The following is a description of a gene set: Induced Treg (iTreg) cells are essential for tolerance and can be used therapeutically, yet their stability in vivo and mechanisms of suppression are unresolved. Here, we used a treatment model of colitis to examine the role of autologous IL-10 in iTreg cell function. Mice treated with IL-10+/+ iTreg cells in combination with IL-10–/– natural Treg (nTreg) cells survived and gained weight, even though iTreg cells were numerically disadvantaged and comprised just ~20% of all Treg cells in treated mice. Notably, ~85% of the transferred iTreg cells lost Foxp3 expression (ex-iTreg) but retained a portion of the iTreg transcriptome which failed to limit their pathogenic potential. The TCR repertoires of iTreg and ex-iTreg cells exhibited almost no overlap, which indicates that the two populations are clonally unrelated and maintained by different selective pressures. These data demonstrate a potent and critical role for iTreg cell produced IL-10 that can supplant the IL-10 produced by nTreg cells and compensate for the inherent instability of the iTreg population. from publication Schmitt EG, Haribhai D, Williams JB, Aggarwal P, Jia S, Charbonnier LM, Yan K, Lorier R, Turner A, Ziegelbauer J, Georgiev P, Simpson P, Salzman NH, Hessner MJ, Broeckel U, Chatila TA, Williams CB (PMID 23125413) Genes down-regulated in comparison between in vitro derived induced T reg (iTreg) and converted ex iTreg. Human Gene Set: GSE35543_IN_VITRO_ITREG_VS_CONVERTED_EX_ITREG_DN studied in species Homo sapiens, and this is the list of marker genes: HOXA7, ATP11A, CCDC187, CXXC5, FNDC10, IFITM10, PEX11A, ARPC3, CABP4, GABRP, BMP6, DSG1, LPAR1, ICAM2, ENSG00000286190, GJA1, KRT31, NCS1, MINAR2, GNB5, TPST2, ECE1, POLD4, GRAMD4, CHCT1, SLC14A2, RASGEF1A, FYTTD1, TRIML1, DCAF11, TMEM191C, ST6GALNAC6, EGR2, PXMP2 (peroxisomal membrane protein 2), HOXA11, TSPAN5, LAG3, CRTAM, FMC1, ARID5B, NDUFS5, CORO2B, SLC48A1, TIMM8B, FHL2, SLC39A4, HLA-DQA1, RGL1, PAPSS1, SIPA1L3, ABCG5, MAGI1, MCOLN1, EPHB3, VSNL1, MTSS1, ZDHHC11, MRPS33, ZYX, NDFIP2, DGKZ, IKZF3, HPCAL1 (NCBI Gene Id 96763), MC5R, SLC15A3, ZFP36, SCN1B, TRIM8, TSPAN15, CAPN8, CD320, HOXD8, PENK, PRKN, HOXA1, KRT18, TMEM208, VPS29, GABRA1, PRRG2, DCLK1, CSNK2B, ADGRE5, NICN1, PPP3R1, NDUFS2, AP4S1, LDLRAD3, TMEM121B, RFTN1, TMEM115, MFNG, RBPJ, CD68, TIMP1, GLRX2 (glutaredoxin 2), MCRIP2, AKT2, FOXN1, IL27RA, MFSD13A, SLC22A9, CCR3, OTOR, SLC7A11, SULF1, HAPLN2, LGALS3, PFKM, ISYNA1, URGCP, COQ4, TCP11L2, BORCS6, CCL1, NAA10, LTBP3, HBG2, TCTA, C16orf90, SMPDL3B, CALU, PNKD, ADGRL1, RHOT2, GPRC5C, FBXO36, CDK3, CHIT1, NNMT, ANXA8, CCL24, COMMD10, BTBD19, KLF9, DIP2B, FAM171A2, ACY3, TMBIM1, SZRD1, TOB1 (transducer of ERBB2, 1), CERS3, TAGAP, ARHGEF33, ROBO4, CRABP2, SPNS2, AP3S1, SLC18B1, ACTC1, PCDH7, TMEM42, LRFN1, UBL7, GSTT1, SSPN, NSMF, BTBD9, ROPN1, TATDN3, PRKG2, STAT5A, FAM241A, GPR176, NACAD, RNF19A, OR10AD1, ADPRHL1, JUND, ARC, FGF2, GRSF1, TSPO, COMTD1, ARL3, CNIH2, ALDOC, UGGT2, METTL26, HMX3, GPD1, CPNE8, COPS6, TXNDC5, KRTAP4-12, IL4, SLC29A1, MMRN2, SUCLG1, BIN3, RNF32, CHST11, HOPX, SNX15, GAST, RRP8, NT5DC1, PI4KA